The following is a description of a gene set: Mouse Gene Set: chr6D3 species: Mus musculus, and this is the list of marker genes: Pdzrn3, Gm19653, 4930595L18Rik, Gm26175, Gm19692, 9530086O07Rik, Gm33201, Gm7838, Nup50l, Rybp, Gm32453, 4930587E11Rik, Tafa1, Btf3-ps6, Foxp1, Tafa4, Prok2, Gm44196, Gm26011, Tmf1, Gm18422, 2010109P13Rik, Shq1, Gm26748, Gm22971, Lmod3, Gm23234 (predicted gene, 23234), Ppp4r2, Eogt, Gm15531, Gm6565, Gm7924, Eif4e3, Gm32381, Tpt1-ps3, Gm32592, Mitf, Gm32308 (predicted gene, 32308), Uba3, Gm26022, Cntn3, Gxylt2, Gm6681, Gm19726, Gm25852, Mir6373, Gm23703, Mdfic2, Gm9871, Arl6ip5 (ADP-ribosylation factor-like 6 interacting protein 5), 4930595O18Rik, Gm26911, Gpr27, Gm5881, 1700049E22Rik, Gm15576, Frmd4b